Given this list of marker genes Entpd7, Entpd4, Entpd8, Entpd2, Entpd4b, Entpd3, Entpd1, Entpd5, Entpd6, here is a description of the gene set: Phosphate bond hydrolysis by NTPDase proteins studied in species Mus musculus Mouse Gene Set: REACTOME_PHOSPHATE_BOND_HYDROLYSIS_BY_NTPDASE_PROTEINS